Given this list of marker genes F2RL1, EMILIN1, SPINK5, KLK7, PGC, ARG2, SYT11, KLK3, FOXP1, MIR181B1, KLK5, MAPKBP1, SIGLEC16, NLRP10, MMRN2, EMILIN2, HAVCR2, GRN, CYBA, here is a description of the gene set: studied in species Homo sapiens Any process that modulates the frequency, rate or extent of defense response to bacterium. Human Gene Set: GOBP_REGULATION_OF_DEFENSE_RESPONSE_TO_BACTERIUM